The following is a description of a gene set: Any process involved in the maturation of a precursor Small SubUnit (SSU) ribosomal RNA (rRNA) molecule into a mature SSU-rRNA molecule. Human Gene Set: GOBP_MATURATION_OF_SSU_RRNA studied in species Homo sapiens, and this is the list of marker genes: FCF1, RPP40 (ribonuclease P/MRP subunit p40), SNU13, UTP3, UTP4, ERCC2, RIOK2, UTP25, RIOK1, KRI1, DHX37, NOL10, BMS1, WDR3, PWP2, NOP14 (NCBI Gene Id 8602), LSM6, NOL11, MPHOSPH10, RIOK3, GTF2H5, NOP9, RRP36, TSR3, ABT1, IMP4, BYSL, TRMT112, WDR43, RPS14, RPS21, IMP3, UTP23, TSR1, NAT10, DCAF13, RPS16, RPS8, RPS19, HEATR1, TBL3, UTP20, DDX52, NOL7, WDR46 (WD repeat domain 46), NOB1, RPS28, NGDN, TSR2, RRS1, UTP6, SRFBP1, SLX9, RCL1 (NCBI Gene Id 94533)